Given this list of marker genes Sacm1l (SAC1 suppressor of actin mutations 1-like (yeast)), Shisa7, Tfrc, Hspd1, Zap70, Ryk, Il23r, Acvrl1, Ceacam1, P2rx2 (NCBI Gene Id 231602), Plxna3, Nr3c2, Ros1, Chrne, Gabrg3 (gamma-aminobutyric acid type A receptor, subunit gamma 3), Itga8, Smad3, Fgfr4, Amn, Itga9, Ly96, Hsp90ab1, Npr1, Caprin2, Insr, Itgb6, Chrna7, Itgae, Erbb3 (erb-b2 receptor tyrosine kinase 3), Cd36, Gria3, Cd3e, Gprc5d, Plp1, Itgax, Fgfr1, Ephb4, Trbv19, Chuk, Ramp2, Chrnd, Nrn1, P2rx6, Nbr1, Pth1r, Kctd8, Diablo, Emilin1, Lrp8, Tgfbr1, Shisa6, Cnih3, Il6ra, Eps8, Tnfrsf1a, Pmp22, Ghr, Igf1r, Gdnf, Trat1, Plxdc1, Htra2, Gpr84, Itga5, Gfra3, Trbc1, Pex5l, Slitrk5, Tie1, Gfra1, Olfm3, Plxnb3 (plexin B3), Ceacam2, Cacng3, Chrnb3, Cd79a, Acvr1b, Htr2c, Gpr37, Cacng2, Cd79b, Drd2, Vwc2, Gpr156, Tek, Itpr3, Gria4, Vdr, Lyn, Chrnb4, Hfe, Ptpra, App, Itgb3, Il12rb1, Bmpr1a, Mcoln1, Cacng7, Htr2b, Alk, Abcg5, Scimp, Cd74, Adrb2, Plxnd1, Plxnb2, Trav18, Gp5, Olfm2, Klrc2, Il5ra, Cd3g, Trpv3, Notch2, Gabrb1, Cr2, Traf3, Ntrk3, Bmpr1b, Bmp2, Prlr, Grm1, Gpr160, Dlg4, Met, Itgal, Gabrq, Tyro3, Htr3b, Flt1, Ticam2, Drd1, Calcrl, Gria2, Jak2, Itgb1, Gabbr1, Ptprq, Klrc1, Nlgn1, Grik3, Htr3a, Il11ra1, Ror2, Itgb2, Birc2, Chrnb1, Ahrr (NCBI Gene Id 218337), Trac, Grin2b, Flt3, Aip, Itgb5, Grin3b, Htr1b, Itgam, Cd200r1, Fshr, Fgfr3, Mertk, Grm7, Bmal2, P2rx3, Cacng8, Ret, Loxl4, Tgfbr2, Adrb3, B2m, Cacng4, Tril, Calcr, Ighd, Epha1, Csf2rb, Erbb2, Grik2, Gpr63, Gabra3, Adra2a, Lifr, Grin3a, Taok2, Dlg3, Gprc5b, Itga10, Lrp5, Il13ra1, Lepr, Itga1, Gprc5a, Ramp3, Pdgfrb, Nt5dc3 (NCBI Gene Id 103466), Gpr119, Itgad, Csf1r, Tradd, Chrna3, Traf6, Klrd1, Ikbkb, Mttp, Gpr20, Gabrg2, Itga3, Chrng (cholinergic receptor, nicotinic, gamma polypeptide), Ifnl2, Gp9, Chrna1, Trf (transferrin), Acvr1c, Gpr61, Erbb4, Itgbl1, Itgb7, Pkd1l3, Gp1bb (glycoprotein Ib, beta polypeptide), Gp1ba, Gabrg1, Syk (NCBI Gene Id 20963), Traf2, Axl, Cnih2, Cpt1c, Gria1, Gfra2, Alcam, Itga11, Tlr4 (NCBI Gene Id 21898), Nr1h3, Epha5, Epha2 (Eph receptor A2), Grik1, Ldlr, Itga7, Tfr2, Tshr, Ifnlr1, Itga2, Chrna4, Itpr2, Itgb4, Abcg8, Traf5, Tgfbr3, Chrna5, Rnmt, Il2rg, Csf2ra, Il6st, Acvr2a, Itga6, Tlr6, Ltk, Lrrtm4, Gh, Itgb8, Gabra4, Gabbr2, Trbc2, Acvr2b, Gabrp, Osmr, Tlr1, Grid1, Gfral, Cd8b1, Ighm, Cntfr, Ntrk1, Gprc5c, Il6, Plxna2, Chrna2, Ahr, Flt4, Olfm1, Il18rap, Lhcgr (luteinizing hormone/choriogonadotropin receptor, NCBI Gene Id 16868), Itga4, Il12rb2, Cd8a, Flna, Egfr, Csf2rb2, Ighe, Gabra1, Lrp2, Fcrl5, Acvr1, Amhr2, Lime1, Abhd6, Ddr2, Gabrr2, Gabrr1, Vldlr, Htr2a, Pkd2l1, Abhd12, Gabra6, Pla2r1, Il18r1, Cubn, Arnt, Kit, Skap1, Arnt2, Tas1r2, Cd44, Grin2d, Adcyap1r1, Vipr1, Iglc1, Gpbar1, Gabre, Il13ra2, Ptk2b, Ddr1, Eng, Plxnc1, Gabrr3, Gpr62, Ptprb, Olr1, Insrr, Tspan32, Kctd12, Lrp1, Tnfrsf11b, Chrna6, Grin2a, Chrnb2, Crlf1, Gabra5, Csf2, Bmpr2, Cd14, Itgb2l, Ifnl3, Itgav, Col10a1, Pparg, Kdr, Ripk1 (receptor (TNFRSF)-interacting serine-threonine kinase 1), Tlr2, Lrp1b, Cd247, Ptpn6, Ptprn2, Sdcbp, Tlr7, Plxnb1, Itln1, Rnf31, Grik4, Kctd12b (potassium channel tetramerisation domain containing 12b), Rxra (retinoid X receptor alpha), Tas1r3, Trpc1, Impg2, Gabrb3, Cr1l, Gpr37l1, Itga2b, Kctd16, Gpr101, Pigr, Tm7sf2, Gabrd, Tyk2, Ror1 (NCBI Gene Id 72176), Stxbp5, Adgrv1, Nr1h4, Chrna9, Plxna1, Igkc, Porcn, Mst1r, Grin2c, Il31ra (interleukin 31 receptor A), Il4ra, Il11ra2, Gabrb2, Cd40, Sema4d, Grin1, Hjv (NCBI Gene Id 99714), Cd6, Plxna4, Grid2, Pdgfra, Bmal1, Irs1, Cacng5, Ntrk2, Vwc2l, Gabra2, Shisa9, Musk, Grik5, Apbb1ip, Notch1, Ramp1, Fgfr2 (NCBI Gene Id 20946), Cd3d, Notch3, Gfra4, Shisa8, Mtnr1a, here is a description of the gene set: species: Mus musculus Mouse Gene Set: GOCC_RECEPTOR_COMPLEX Any protein complex that undergoes combination with a hormone, neurotransmitter, drug or intracellular messenger to initiate a change in cell function.